Given this list of marker genes PDIA3, PLCXD3, GDPD5, PLCD3, GDPD4, GPLD1, PDGFRB, PDGFRA, PLCH1, PLCZ1, PLCB1, CHRM1, PDE4C, PLD3, SMPDL3B, PDE10A, TDP2, PDE7B, PDE9A, PLCD4, PLCL2, SNCA, GDPD3, SMPD3, CCR1, ENPP1, PDE6G, ENPP3 (NCBI Gene Id 5169, ectonucleotide pyrophosphatase/phosphodiesterase 3), F2RL2, PDE1A, PDE6A, MPPE1, ARL1, SMPD2, CHRM5, FAN1, PLCB3, CASR, CCR5, CCL5, PLCXD1, PLCD1, CNP, ARF4, PDE7A, NOTUM, PDE6B, PDE8B, MPPED2, PDE4A, PDE4D, SMPD1, STX4, HRAS, PLCB2, PDE6H, ADPRM, EDNRA, SMPD4, PLCH2, PLCL1, ENPP6, PDE6C, APEX1, ENPP2, PLCE1, PDE5A, TDP1, ENPP7, PDE11A, BDKRB2, APEX2, PDE8A, PDE4B (NCBI Gene Id 5142), PLCG2, FAM83B, PDE1C, PLD6, PDE1B, PLCB4, GDPD2, CHRM3, GDPD1 (NCBI Gene Id 359824), PDE2A, PLD1, PLD4, PLCXD2, GDE1, PLD2, GPCPD1, PDE3B, PLCG1, PDE3A, SMPDL3A (sphingomyelin phosphodiesterase acid like 3A), FICD, NAPEPLD, here is a description of the gene set: Catalysis of the hydrolysis of a phosphodiester to give a phosphomonoester and a free hydroxyl group. studied in species Homo sapiens Human Gene Set: GOMF_PHOSPHORIC_DIESTER_HYDROLASE_ACTIVITY